Given this list of marker genes NGRN (neugrin, neurite outgrowth associated), TGIF1, ZNF506, MAD2L1BP, CFL2 (NCBI Gene Id 1073), CCDC59, RBM15 (RNA binding motif protein 15), MED21, RNF19A (NCBI Gene Id 81036), KLHL15, ZNF282, ESCO1, CD83, CREM, INSIG1, YTHDF3, MUL1, BCL6, ETF1, EPG5, PTX3, WTAP, FKBP15 (FKBP prolyl isomerase family member 15), LCOR, RAP2C, MED30, SERTAD1, DUSP5, SP100, FAM117B, HEG1, KBTBD2, LRRFIP1, NFKBIE, MAP3K8, IRF2BP2, ARL4C, LONRF1, HBEGF, KAT7, ZBTB10, PDZD8, HCAR3, SMAD4, RGS1, ZNF267, METRNL, USF3, SLC25A30, MEF2D, GPR18, PGGT1B, SPTY2D1, RBM33, ADO, ZNF350, GABARAPL3, KLF11, DNAJB9, SIK1, RBM7, ICAM1, EIF5 (eukaryotic translation initiation factor 5), IFNGR1 (interferon gamma receptor 1), AREG, PRKAR1A, CDK17, PHACTR1, EGR2, TENT5A, KLF4, CYLD, FAM53C, PTPRE, WASL, CDKN1A, CREBRF, MALAT1, GABARAPL1, SRSF3, SCAF11, NFE2L2 (NCBI Gene Id 4780), GZF1, PDP1, B3GNT5, PWWP2B, JUND, MSL2, BCOR, DYNLL2, SLC16A6, QKI, OTUD1, TSC22D2, ZBTB43, JMJD6, SAT1, CHORDC1, C2orf49 (NCBI Gene Id 79074), RBM18, BCL2A1, RNF138, RELT (RELT TNF receptor), STK39, C11orf58, FOS, PPP2R2A, RASGEF1B, CSRNP1, ZNF644, FEM1C, MAPK1IP1L, ELF1, C9orf78, PPP1R15B, MAFB, NR4A2, MCM9, JUNB, TRAF6, RPS24, FOSB, FOSL2, RIPK2, MEX3C, IVNS1ABP, RLIM, RBBP6, CXCL16, CXCL2, HSPA14, SERTAD3, ZFC3H1, TNFRSF21, DICER1, C15orf39, NFIL3 (nuclear factor, interleukin 3 regulated), RICTOR, DUSP1, BCL10, CHMP1B, PTP4A1 (NCBI Gene Id 7803), SOCS3, YES1, CLK4, NUB1, CALCOCO2, ATP1B1, RHOB, KDM7A, YPEL5, ARMC8, ATXN7, ABHD13, PPM1D, ENPP4, TENT4B, PCGF5, CACUL1, ETV3, LATS2, RAB20, JMJD1C, ZXDA, EXOC8, OSM, USP42, SAMSN1, TPM3, ENC1, WDR48, SNHG15, CDADC1, CHMP2B, NCAM1, CHD1, DDX21, SNIP1, FTH1, PTGER4 (NCBI Gene Id 5734), EGR3, CCL3, MAFF, ZFP36, PMAIP1, RAB18, ZBTB1, ATF3, SRGAP2, NSF, RBM38, ZNF281, HNRNPC, ZNF92, ASH1L, NR4A1 (NCBI Gene Id 93352), ITPRIP, EPS8, UQCRC2, ZCCHC2, ELK4, CTNNB1, SERTAD2, RGS2, PTGS2, ZNF703 (zinc finger protein 703), ASCC3, PRP4K, HERC4, NR4A3, C9orf72, ZNF326, CD6, EGR1, COX17, MAFK, BAG5, CPEB2, MIR23AHG, NLRP3, PPM1A, CCL3L3, MNT, PLAUR, FGFR1, ARL4A, GADD45B, MTMR6, GCC1, ZBTB21, RAB8B, PPP1R15A, ETNK1, SPOPL, ZBTB33, RAB11FIP4, IDI1, TIGAR, JARID2, VEGFA (vascular endothelial growth factor A), SOCS1 (suppressor of cytokine signaling 1), BTG2, HLA-F, SNX13, RAB12, CXCL8, SP3, FBXL3, TSPYL1, RNF139, NUDT15 (NCBI Gene Id 55270), GPATCH2L, IL1B, HAVCR2, USP30, CLEC2B, PFKFB3, LYN, SAMD8, UTRN, ZC3HAV1, ARIH2, XPR1, PDE4D, KCNS2, SPIDR, THBS1, ZFAND5, L3MBTL3, NAMPT, CD55, TRIB1, KBTBD8, MCL1, CRY1, C5AR1, here is a description of the gene set: Here we have used a systems biology approach to study innate and adaptive responses to vaccination against influenza in humans during three consecutive influenza seasons. We studied healthy adults vaccinated with trivalent inactivated influenza vaccine (TIV) or live attenuated influenza vaccine (LAIV). TIV induced higher antibody titers and more plasmablasts than LAIV did. In subjects vaccinated with TIV, early molecular signatures correlated with and could be used to accurately predict later antibody titers in two independent trials. Notably, expression of the kinase CaMKIV at day 3 was inversely correlated with later antibody titers. Vaccination of CaMKIV-deficient mice with TIV induced enhanced antigen-specific antibody titers, which demonstrated an unappreciated role for CaMKIV in the regulation of antibody responses. Thus, systems approaches can be used to predict immunogenicity and provide new mechanistic insights about vaccines. studied in species Homo sapiens Human Gene Set: NAKAYA_PBMC_FLUARIX_FLUVIRIN_AGE_18_50YO_7DY_DN Genes down-regulated in peripheral blood mononuclear cell 7d vs 0d in adults (18-50) after exposure to Fluarix/Fluvirin, time point 7D. Comment: Supplementary Table 1a: All the differentially expressed genes identified in PBMCs of TIV vaccinees. from publication Nakaya HI, Wrammert J, Lee EK, Racioppi L, Marie-Kunze S, Haining WN, Means AR, Kasturi SP, Khan N, Li GM, McCausland M, Kanchan V, Kokko KE, Li S, Elbein R, Mehta AK, Aderem A, Subbarao K, Ahmed R, Pulendran B (PMID 21743478)